The following is a description of a gene set: The aggregation, arrangement and bonding together of a set of components to form the spindle, the array of microtubules and associated molecules that serves to move duplicated chromosomes apart. Human Gene Set: GOBP_SPINDLE_ASSEMBLY studied in species Homo sapiens, and this is the list of marker genes: HSPA1A, CCDC69, BCCIP, CHMP5, RPS3, TUBGCP4, TUBB8, FBXO5, LZTS2, INCENP, RIPOR2, RCC1, HAUS4, TNKS, CDCA8, KIF23, FLNA, GTF2B (general transcription factor IIB), SKA2, RAB11A, MZT1, DRG1, SAC3D1, PTEN, KIF4B, CEP192, KIF11, NEK2, ABRAXAS1, CHMP4C, SPAG5 (sperm associated antigen 5), CHMP6 (NCBI Gene Id 79643), HSPA1B, CEP97, HAUS5, MAPRE2, MAPK15 (NCBI Gene Id 225689), CCNB2, MAP9, ZNF207, MISP, KIF15, ASPM, CCDC61, PPP2R1B, KIF2A, TUBGCP6, TUBB, ARHGEF10, AURKB, CENPJ, RNF4, VPS4B, PDCD6IP, STAG1, CHMP2A, CCSAP, PPP2R1A, RACGAP1, SENP6, KIF3B, NEK6, NUMA1, BIRC5, STAG2, CHMP2B, HAUS7 (HAUS augmin like complex subunit 7), PLK1, HAUS1, WRAP73, PRICKLE1, CHMP4B, PIBF1, TPX2, CSNK1D, AURKA, CHMP1A, TPR, KIF4A, KPNB1, CHMP7, KIFC1, RHOA, CCDC66, TUBGCP2, HAUS6, STIL, KASH5, HAUS3, UHRF1, MAP10, ABRAXAS2, HDAC3, CLASP2, NDC80, MAPRE3, TUBB1, DYNC1H1, INO80, CHMP1B, AURKC, SMC1A, CEP63, LSM14A, RANGRF, SKA1, BCAS2, WASHC5, MYBL2 (NCBI Gene Id 4605), NCOR1, HAUS8, POLDIP2, TUBGCP5, NEK7, HNRNPU, AAAS, SMC3, DCAF13, SASS6 (SAS-6 centriolar assembly protein), PRC1, STARD9, SEPTIN1, DDB1, CHEK2, GOLGA2, CLASP1, TUBGCP3, EML3, MLH1, SKA3, OFD1, SPICE1, CHMP4A, CHMP4BP1, HAUS2, GPSM2, CDC20, CHMP3, MAPRE1